The following is a description of a gene set: species: Mus musculus from publication Cui A, Huang T, Li S, Ma A, Pérez JL, Sander C, Keskin DB, Wu CJ, Fraenkel E, Hacohen N (PMID 38057668) Genes negatively differentially expressed in cell type: MigDC (migratory dendritic cell) upon treatment with cytokine: IL-17C in mouse lymph nodes in vivo. Cytokines mediate cell-cell communication in the immune system and represent important therapeutic targets. A myriad of studies have highlighted their central role in immune function, yet we lack a global view of the cellular responses of each immune cell type to each cytokine. To address this gap, the authors created the Immune Dictionary, a compendium of single-cell transcriptomic profiles of more than 17 immune cell types in response to each of 86 cytokines (>1,400 cytokine-cell type combinations) in mouse lymph nodes in vivo. A cytokine-centric view of the dictionary revealed that most cytokines induce highly cell-type-specific responses. For example, the inflammatory cytokine interleukin-1β induces distinct gene programmes in almost every cell type. A cell-type-centric view of the dictionary identified more than 66 cytokine-driven cellular polarization states across immune cell types, including previously uncharacterized states such as an interleukin-18-induced polyfunctional natural killer cell state. Mouse Gene Set: CUI_MIGDC_IL17C_RESPONSE_DN, and this is the list of marker genes: Hspa1a, Hspa1b, Rgs1, Fosb, Fos